The following is a description of a gene set: Human Gene Set: GOBP_REGULATION_OF_CELL_ACTIVATION studied in species Homo sapiens Any process that modulates the frequency, rate or extent of cell activation, the change in the morphology or behavior of a cell resulting from exposure to an activating factor such as a cellular or soluble ligand., and this is the list of marker genes: CD80, PTPRC, IL12RB1, FBXO38, MFHAS1, TNF, FCHO1, RIPK3, MMRN1, ZBTB46, MILR1, GP9, IFNB1, CEACAM1, PHF10, LBP, TYRO3, ZNF335, RHOA, NEDD9, PJA2, CRLF2 (NCBI Gene Id 64109), LAX1, SLC7A1, ZNF683, CCL21, ATAD5, CAMK4, TCF3, TTBK1, IL1B, AIF1, MIR21, FGF10, ZBTB7B, VAV3, SLC46A2, FCER1G, CORO1A, SMARCD2, MIR92A1, IDO1 (NCBI Gene Id 3620), HRG, BTNL2, NDFIP1, IL1RL2, ADA (adenosine deaminase), CTLA4, ACTB, UFL1, XRCC6, PLA2G4A, MMP8, LRRK2, STAT5A, MTOR, MIR145, DROSHA, EFNB1, PRKCA, CNR2, CD9, CHRNB2 (cholinergic receptor nicotinic beta 2 subunit), IRGM, CALHM2, GCLC, ARID2, DPP4, CLC, CAV1 (NCBI Gene Id 857, caveolin 1), EP300, GAS6, IL33, F2, TNFSF9, HLA-E, FLT3LG, BRD4 (NCBI Gene Id 90616), FOXJ1, PRKCZ, TBC1D10C, GPER1, LOXL3, TNFSF18, MPL, SHLD3, PTPRJ, MZB1, FGR, RASSF5, SART1, PRKCD, RHOH (NCBI Gene Id 399), KLRC4-KLRK1, IL16, HLA-DRB3, GP6, ARID1A, FBXO7, SMARCA2, LYN, NFKBIZ, TNFSF13, BATF, THBD, CD28, DTX1, UBASH3B, TAFA3, HLA-DOB (major histocompatibility complex, class II, DO beta), B2M, CD300LF, RAG1, RIPK2, IFNA2, TNFSF11, SMAD7, LDLR, TNFRSF13C, CD55, MIR27A, CD1D, ICOSLG (inducible T cell costimulator ligand), HLA-DRA, PDPN, RASGRP1, TGFB1, TFRC, KAT5, CD69, NCKAP1L, PGLYRP2, CDKN1A, OPA1, ZFP36L1, BCL2, RPS6KA1, PRDX2, GPNMB, PELI1, FCGR2B, BTK, IL12B, SFRP1, IL31RA, AKIRIN2, HLA-A, ATM, IL23R, HTR2A (NCBI Gene Id 3356), LMO1, PBRM1, CD200, CLNK, CCR7, TNFRSF21, RUNX3, CD5, LILRB4, SIRPB1, CD209, ABL1, FGL1, RIPOR2, SHLD1, APOE, GPR183, CX3CL1, CD37, EGR3, TP53BP1, ADGRG1, HLA-DMB, KITLG, SPN, TARM1, IL5, PSG9, BST1, GLI3, YES1, ADORA2A, BTLA, PRLR, FLOT2, CBLB, CLEC7A (C-type lectin domain containing 7A), ANXA1, TACR1, MERTK, AP3D1, SPHK1, CASP3, PLSCR1, CEBPB, HES1, GRN, ZEB1, HLA-DQA2 (major histocompatibility complex, class II, DQ alpha 2), CCL2, PDGFA (NCBI Gene Id 5154), GPR137B, CTSC, CELA2A, CD84, ZFP36L2, GNRH1, TNFSF13B, SH3RF1, YWHAG, LGALS8, CLPTM1, PKN1, GPR65, TNFSF14, WNT10B, GP5, BMI1, HAVCR1, LAG3, RPL13A, SH2B3, RAC2, AXL, EMILIN2, CRTAM, PRKCQ, F11R, NFATC2, PIK3CD, KLRC1, RPS3, PRELID1, ARID1B, HAVCR2, BPI, IRF4, LEF1, HMCES, PLPP6, DDR2, SMARCE1, ID2, BLOC1S6, IRS2, HHLA2, TMX1, MAD2L2, TNFSF4, RNF41, SCRIB, FYN, PYCARD, ENPP3, CCL19, PAXIP1, LGALS9C, EFNB2, CD46, PAG1, PIK3R6, KCNK18, ITPKB, LST1, SFTPD, BAD, SHLD2, AGER, SMARCB1, CD83, NSD2 (nuclear receptor binding SET domain protein 2), EXOSC6, GJD4, IHH, IKZF3, IL12A, GP1BB, TLR4, ADAM8, LGALS3, CD300A, ARG2, CYP26B1, TYROBP, IL15, TIRAP, DLG1, PTPN22, NECTIN2, SOCS1, SOX13, MIR130A, TNFRSF9, PGLYRP1, BRAF, SOCS6, VSIR, PDCD1, PTPN2, SMARCD3, NR1D1, EPHB2, IL1RL1, MARCHF7, MDK (NCBI Gene Id 4192), WNT3A, TNFAIP8L2, PIBF1, KMT5C, KLRC3, EBI3, SH3KBP1, IRF1, HLA-DRB5, SIRPA, SOS1, CCL3, TMEM131L, DUSP3, SOS2, CD38, LILRA2, TLR6, PAWR, WNT5A, ZBTB16, THEMIS2, IGF2, IL4, TNFRSF4, SDC4, MMP14 (matrix metallopeptidase 14), CBFB, LRFN5, PLA2G5, TMIGD2, PGLYRP3, CGAS, ACTA2, BLOC1S3, TICAM1, CYRIB, CD81, RC3H2 (ring finger and CCCH-type domains 2), IL13, ACTL6B, TSLP, SMARCD1, VTCN1, IL7, HMGB1 (NCBI Gene Id 3146), DHPS, TNIP2, ZC3H8, DUSP10, PRKAR1A, LILRA5, TREX1, ILDR2, FGL2, SMARCC1, AP3B1, RASAL3, LGALS9, VSIG4, MCUB, ZP3, ALOX12, MIR17HG, MLH1, VAV1, LILRB1, CSK, NCK1, CD320, IL6ST, IL2RG, IL1A, HLA-DMA, PDGFRA, NR1H3, CDKN2A (NCBI Gene Id 1029), CTSG, PCID2, CD40LG, IL20RB, SYK, FOXO3, SHB, ARG1, SNCA, PDGFB, BTN2A2, XBP1, LGALS1, IL4I1, CD19, FLNA, SHH, IL2RA, PRKG1, IGF1, CD74, ITCH, TEC, KARS1 (NCBI Gene Id 3735), PRKAA1, CD33 (CD33 molecule), CD2, CD276, GATA3 (NCBI Gene Id 84828), PARP3, FAM76B (NCBI Gene Id 143684), INPP5D, SELP, IL15RA, PTPN6, PNP, CR1, CD22, ZP4, SHPK, IL36B, FANCA, EXOSC3, JUND (NCBI Gene Id 3727), PDCD1LG2 (programmed cell death 1 ligand 2), KLRD1, PRNP, NRARP, MIR142, INHA, TNFAIP3, SOX12, TBX21, THBS1, KLRC2, LEP, SIT1, ACTL6A, GLI2, PPP2R3C (protein phosphatase 2 regulatory subunit B''gamma), CD27, SPHK2, PTPN11, TNFRSF14, SLAMF1, FCRL3, CD226, MIR181B1, RIF1, SLC4A2, BMP4, KMT5B, TESPA1, TREM2, DUSP22, IL21, IL2, CYLD (CYLD lysine 63 deubiquitinase), KLHL25, IL7R, HLA-DQB1, CLEC4G, TSPAN32, JAK3, SMARCC2, HLA-DQB2, IL18 (NCBI Gene Id 3606), FUNDC2, HSPH1, HLA-DQA1, AMBRA1, CD6, ICOS, LAT, GP1BA, DAPL1, CARD11, CEBPA (NCBI Gene Id 1050), MYB, SOX4, CYGB, BCL10, ADAMTS18, GPAM, IL23A, SMARCA4, CLCF1, TNFSF8, MAP3K8, GLMN (NCBI Gene Id 11146), IFNL1, SOCS5, TGFBR2, RAG2, STAT5B, ZMIZ1, MAPK8IP1, CD24, KAT2A, MICA, IL6, IFNG, MIR30B (NCBI Gene Id 407030), TAC1, JAK2, INHBA, MIR128-1, TIGIT, DOCK8, LAPTM5, NFKBID, MIR125A, BID, EFNB3, MSH2, CD70, TCF7, SPTA1, ZBTB1, LILRB2, TLR9, PMS2, SPI1, PCK1, LRRC32, NFAM1, ERBB2, SPACA3, RC3H1, ABL2, HLA-DPB1, BANK1, LMO4, FADD, MNDA, MIR185, SIRPG, TWSG1, NCK2, SYT11, RORA, LGALS9B, C1QTNF1, CCR2, MYO18A, THY1, SELENOK, PRKDC, FOXN1, MFSD2B (NCBI Gene Id 388931), NLRP3, TNFRSF13B, NR5A2, SOX15, NR4A3, HLA-G, FOXP3, HLA-DRB1, DCAF15, CD4, SRC, MIF, LCK, BRD2, ADGRF5, EPO, HLA-DPA1, CD47, NOD2, TRAF6, RABGEF1, ZC3H12A, GAL, CTNNB1, STAT6, DDRGK1, FCGR3A, CD86, CD3E, RUNX1, PTPRE, NOS3, CLEC12A, HFE, RHBDD3, CAPN3, MALT1, ZNHIT1, CLEC4D, METTL3, PLA2G2D, CD160, TOX, HLA-DRB4, HMGB3, DNAJA3 (NCBI Gene Id 94389), ZAP70, HLX, PLA2G2A, MIR181C, FER, APLF, EMILIN1, CCDC88B, PEAR1, JUNB, APP, BRD7, MEF2C, VNN1, SLAMF8, SAMSN1, DLG5, SVEP1, SOX11, IL6R, CD40, AHR, VCAM1, TYK2, GNAQ, MYD88, FANCD2, PLA2G2F, SLC15A4, PRDM1, KLRK1, VPS33B, SPINK5, ASCL2, CLECL1P, STAP1, HLA-DOA, BCL6, SLC39A10, IL4R, PLEK, RARA, FN1 (NCBI Gene Id 2335), TNFRSF1B, IL10, KLHL22, IGFBP2, CD274, MAD1L1, SERPINE2, PLA2G10, CCL5, AKT1, SOD1, IL27RA, SCGB1A1, PPP3CA, SUPT6H, XCL1, NKAP, HSPD1, CST7, SASH3, IL27, PDPK1 (NCBI Gene Id 5170)